The following is a description of a gene set: Human Gene Set: GOMF_ABC_TYPE_GLUTATHIONE_S_CONJUGATE_TRANSPORTER_ACTIVITY Catalysis of the reaction: ATP + H2O + glutathione S-conjugate(in) -> ADP + phosphate + glutathione S-conjugate(out). studied in species Homo sapiens, and this is the list of marker genes: ABCC3, RALBP1, ABCC4, ABCC2, ABCC1 (NCBI Gene Id 8133), ABCC6, ABCC11, ABCC10